Given this list of marker genes Dhfr, Mthfd1, Mthfd1l, Atic, Folr1, Gart, Gch1, Slc46a1, here is a description of the gene set: species: Mus musculus The chemical reactions and pathways resulting in the formation of tetrahydrofolate, 5,6,7,8-tetrahydrofolic acid, a folate derivative bearing additional hydrogens on the pterin group. Mouse Gene Set: GOBP_TETRAHYDROFOLATE_BIOSYNTHETIC_PROCESS